Given this list of marker genes GPER1, MC4R, POMC, GRK2, PTGER4, TAAR2, GRK5, PDE10A, ADORA2B, CALCA, AVPR2 (NCBI Gene Id 554), ADRB3, GPR32, GNAT3, GRK3, PTGDR, GPR20, CRHR1, SCT, PRKACB, ADM2, TAAR8, GPHA2, ADRB1, PDE8A, ITGA5, ADORA2A, GPR84, GNG2, TAAR3P, PDE4C, GNB2, PDE2A, GPR39, GHRHR, PDE1A, GNG7, PRKAR2A, DRD1, PDE3B, GPR27, RLN2, TAAR9, GPR83, TAAR6, MC1R, GCGR, MC2R, GNG3, CALCR, ADCY8, PDE7B, GLP1R, GNB4, PDE3A, ADCYAP1, FSHB, CALCB, GNAI3, ADCY9 (adenylate cyclase 9), GPBAR1, GNB1, TSHR, GNAI1, GNAZ, P2RY11, PDE4A (NCBI Gene Id 5141), PRKAR1B (protein kinase cAMP-dependent type I regulatory subunit beta), GPR15, GNB3, GNB5, GPR45, PTH2, GRK6, PDE4D, GPR150 (NCBI Gene Id 387128), GNAS, TAAR1, HTR4, GNG13, NPSR1, IAPP, CRHR2, SCTR, PDE11A, VIP, PDE8B, VIPR2, SRC, GNAI2, CALCRL (NCBI Gene Id 10203), HRH2, ADCY7, ADM, GNG11, RLN3, ARRB2, HTR7, GLP2R, PTH1R (NCBI Gene Id 5745), GNG4, GNGT1, PRKAR2B, PRKACA (NCBI Gene Id 5566), GIP, PTHLH, GNG8, FN1, SHC1, LHB (NCBI Gene Id 3972), GHRH, GCG, INSL3, ADCYAP1R1, GNG5, TSHB, PTGER2, ARRB1, PDE1B, LHCGR, PRKAR1A, VIPR1, ADRB2, PTH, NPS, ADCY5, MC3R, CYSLTR2, PTH2R, GPR176, RAMP2, RAMP3, HTR6, TAAR5, MC5R, GNGT2, CRH, ITGB1, RXFP2, GNG10, GNG12, FSHR, ADCY1, RXFP1, PDE7A, PRKACG, DRD5, GPR25, RAMP1, ADCY4, PTGIR, CGA, ADCY6, GPHB5, GIPR, ADCY2, ADCY3, AVP (arginine vasopressin), here is a description of the gene set: part of: GPCR downstream signalling Reactome Pathway: G alpha (s) signalling events species: Homo sapiens The general function of the G alpha (s) subunit (Gs) is to activate adenylate cyclase, which in turn produces cAMP, leading to the activation of cAMP-dependent protein kinases (often referred to collectively as Protein Kinase A). The signal from the ligand-stimulated GPCR is amplified because the receptor can activate several Gs heterotrimers before it is inactivated. Another downstream effector of G alpha (s) is the protein tyrosine kinase c-Src.